The following is a description of a gene set: Polymorphonuclear leukocytes (PMNs) were obtained from healthy individuals in accordance with protocols approved by the Institutional Review Board for Human Subjects at the University of Minnesota and the National Institute of Allergy and Infectious Diseases. PMNs (107) were combined on ice with live S. aureus (108) or with live or heat-killed A. phagocytophilum (bacteria isolated from 5x106 infected HL60 cells for a ratio of 1 infected HL60 cell: 2 PMNs, ~ 5-20 A. phagocytophilum: PMN) in wells of a 12-well tissue culture plate (pre-coated with 20% autologous normal human serum). Unstimulated control assays received either buffer (for S. aureus comparisons) or clarified HL60 lysate (for A. phagocytophilum comparisons). Plates were centrifuged at 350 x g for 8 min at 4oC to synchronize phagocytosis and incubated at 37 deg. C in a CO2 incubator for the indicated times. At the indicated times, tissue culture medium was aspirated from the plate and PMNs were lysed directly with RLT buffer (Qiagen, Valencia, CA). Purification of PMN RNA and subsequent preparation of labeled cRNA target was performed as described in Methods. Labeling of samples, hybridization of cRNA with HU133A oligonucleotide arrays (Affymetrix, Santa Clara, CA), and scanning were performed according to standard Affymetrix protocols ( http://www.affymetrix.com/pdf/expression_manual.pdf ). Experiments were performed in triplicate, using PMNs from three healthy individuals for each treatment. studied in species Homo sapiens Genes up-regulated in polymorphonuclear leukocytes (3h): control versus infection by A. phagocytophilum. from publication Borjesson DL, Kobayashi SD, Whitney AR, Voyich JM, Argue CM, Deleo FR (PMID 15879137) Human Gene Set: GSE2405_0H_VS_3H_A_PHAGOCYTOPHILUM_STIM_NEUTROPHIL_UP, and this is the list of marker genes: IL11RA, FFAR4, NKAIN4, PTPRZ1 (NCBI Gene Id 7983), SEMA6D, ROGDI, TRIM47, SKAP2, HEY1, MSC, KIAA1614, TXNDC17, ECSCR, DECR1, GALNT18, TTN, PRRG3, DPT (dermatopontin), SH3TC2, RAB11FIP5, FNDC3B, PLA2G4A, PDPN, C2, S100A1, MCCC1, LARP6, RBP1, OCIAD2, SHISA4, GDPD5, CADM4, CASP4, PLD4, AQP1, PLTP, DSTN, IGDCC4, COL4A1, S100A11, LIPH, LAMC2, NRARP, LUZP1, SPINT1, VASH2, SWAP70, RNF144B, ALOX5AP, RRAS, CPT1C, MFGE8, TM4SF5, CDH1, CST3, ERLIN2, DOCK7, PLBD1, ABHD4, ALAS1, GNG11, HTRA1, ACTG2, MMP23B, DUSP4, PAX1, PROS1, CYBB, DLG2, BCAR3, HUNK, GSTT1, MCF2L, FOXN1, KRT20, CTTN, SYNGR2, YAP1, LYN, PTPN3 (NCBI Gene Id 5774), KCTD12, IL13RA2 (interleukin 13 receptor subunit alpha 2), CDCP1, VCL, LARGE1, IGFBP7, CIITA, COL6A3, SERPINE1, PXDN, ASNS, RHOJ, LGR4, TMEM176B, ME1, NCF2, DAAM1, FGFR2, RNF19B, MMP2, MT2A, CRIP3, CASP1, FGD5, TIFA, RAI14, MAPK13, SOWAHB, BSPRY, BGN, CTNND2, CHST11, TMEM26, GPC1, APLP2, TIMP1, CCND1, TTC39A, FNBP1L, TMEM51, KRT5, KDELR1, AOC1, SERPINB1, SLC46A2, SPARCL1, LTBP2, PKP1, GMPR, GNB4, SOD1, LPCAT2, MYH11, NCKAP1, LZTS2, SLC4A11, CCL22, PCLO, DAPK2, ADAMTS9, TRIM29, AMOTL1, THEMIS2, IFITM2, NXN, IL18, TSC22D1 (TSC22 domain family member 1), CLDN7, PLCG2, LAIR1, CTTNBP2NL, ETV6, SLC7A7, CBR3, DSCAML1, LAMP2, EXOC3L4, BOC, ADM, GPX8, PLB1, GRK5, OLFML1, TGM2, PALD1, NAPSA, GJA4, FAM3D, SERPINE2, LPAR1, FXYD6, IRF5, GSTM3, PLS3, COL1A2, CACHD1, KIAA0930, MISP, IL15, SERPING1, PYGL (NCBI Gene Id 5836), IGFBP3, NFKBIA, LYPD2, FCGR2A, GNA14, LY6H, OLFML2A, CSF2RB, PLSCR1, TOR3A, SAA2, FAM89A, RAB34, HTR7, BLNK, CTNND1, LRRK2, HFE, PHLDA3